The following is a description of a gene set: studied in species Mus musculus Mouse Gene Set: GOBP_HEART_GROWTH The increase in size or mass of the heart., and this is the list of marker genes: Prkg1, Agtr2, Pin1, G6pdx, Gsk3a, Ccm2l, G6pd2, Gli1, Gsk3b, Tgfbr3, Erbb4, Adra1a, Pdlim5, Mir208a, Camk2d, Tomm70a, Akap13, Yap1, Mesp1 (mesoderm posterior 1), Ahr, Fgf1, Tgfb2, Ang2, Fgf2, Ccnd2, Prox1, Arid2, Wt1, Tenm4, Sorbs2, Rbpj, Cited2, Ctdp1, Hey2, Slc25a4, Fgf20 (fibroblast growth factor 20), Prkar1a, Dusp6, Gja1, Bmpr1a, Rxrb, Parp2, Vgll4, Dipk2a, Hdac2, Mir133a-2, Adrb1, Abl1, Rxra, Cav3, Rgs2, Pin1rt1, Ccn4, Mef2c, Myh10, Map2k4, Trp73, Kcnk2, Mapk11, Sirt1, Mir1a-2, Pak1 (NCBI Gene Id 18482), Myh6, Hamp, Col14a1, Rbm10, Bmp10, Adra1b, Pi16, Jarid2, Ski, Tbx2, Adprhl1, Tbx1, Edn1, Hamp2, S1pr1, Pten (NCBI Gene Id 70161), Tgfbr2, Zfp418, Meis1, Igf1, Ccnb1, Sav1, Dyrk1a, Mtor, Gata4, Gata6, Cxadr, Ddx39b, Fgfr1, Nkx2-5, Nrg1, Foxp1, Foxc2, Nr3c1, Pim1, Ep300, Cdk1, Ppara, Apc, 2810429I04Rik, Tbx5, Fgf9, Mapk14, Mir133a-1, Smad1, Ncam1, Mapk1, Sirt6, Rgs4, Fes, Fdps, Tgfbr1, Agt, Acacb, Myocd, Nog, Trip10, Ttn, Wnt2, Foxc1, Zfpm2, Heg1, Yy1, Tbx20, Ctnnb1, Rbp4, Notch1, Akap6, Fgfr2